Given this list of marker genes FNBP1, DNAJC9, HES6, RPL28, KIF2A, RHBDL3, MICOS13, MIS18A, ADPRS, TMEM214, MTRES1, RIC8A, PCMTD2, FOXJ2, FAM216A, KIF3A, SH3GL1, MRRF, FIG4, RNF121, RGS2, PDCD6, BET1, WDR45B, YBX1, ZNF395, ACOT13, ZKSCAN5, B3GALNT1, TRPV2, VPS26A, TP53BP1, ENTREP3 (NCBI Gene Id 149536), ELANE, AFF4, RNF138, SLC52A2, LTBR (lymphotoxin beta receptor), BRAP, LRRC40, SIN3A, PPOX, MCM2, OAZ2 (ornithine decarboxylase antizyme 2), ELAC2, ITCH, SEC61B, PARK7, NAGK, TDP2, TOR1A, TUBB2A, PEX12, LIME1, NCAPH, BMS1, JMJD1C, TNRC6A, CHFR, PPM1D, S100A8, HCFC1R1, LMNB2 (lamin B2), STAMBPL1, CKLF, TRIO, SDHAF4, GTF2I (general transcription factor IIi), GRHPR, WNT5A, MORN4, ABHD4, GPAM, TAGLN, ZNF318, TOPBP1, FAM91A1, MRPS12, IDH3G, ATOX1, PEDS1, N4BP2L1, HPF1 (histone PARylation factor 1), CARMIL1, SLC37A2, SCYL1, FITM1, PRKRA, NOL12, PER1, PLIN3, GAS6, CDK16, MRPS7, ZFP90 (NCBI Gene Id 146198), DBNDD2, NEAT1, BCL7B, TCTN3, RANBP10, NDUFA4, UBAC1 (UBA domain containing 1), RPL36, LACTB, RRAGC, NIP7, RCC2, CIBAR1, LZTR1, RPL38, COA6, PRMT3, PELO, SHPRH, ME2, MTIF2, HERC4, MCRIP1, COX6C, WRNIP1, KIN, NFX1, LPGAT1, RIPOR1, RPL26, MTG2, MPG, AURKAIP1, ARMC1, MED29, SPTSSA, SNX21 (sorting nexin family member 21), ARL16, GBA2, ZNF566, METTL9, ABHD17A, TRIM33, TCEA3, FAM50A, POLE3, SMIM19, ALDH1A2, NDUFA11, LMAN2, RAB24, RPL11, CDK1, FBXO25, SLC25A3, CA9, MAP3K11, RNF20, B4GALT3, POLR3G, EMILIN1, NENF, RPA1, RNASE4, ASB6, KPNA2, MED4 (mediator complex subunit 4), OLFM1, ARFIP2, RABL6, TPGS1, TSEN34, DCTN1, CCNB1IP1, GRK2, IER5, SLC30A9, FTSJ1, UBP1, ORMDL1 (NCBI Gene Id 94101), SNAP47, ELP3, AZGP1, RAB3GAP2, ZNF426, BEX3, ACTR8, TPD52L2, SSRP1, ALKBH4 (NCBI Gene Id 54784), NUP133, CBR3, VTI1B, OVCA2, ULK2, ABHD18, MMS22L (MMS22 like, DNA repair protein), C2orf42, LSM14B, BLTP3B, GFER, DNAJC3, BOD1L1, EGLN2, RSPRY1, here is a description of the gene set: Genes up-regulated in macrophages 24h after M. bovis BCG infection: wildtype versus MYD88 knockout. Human Gene Set: GSE22935_WT_VS_MYD88_KO_MACROPHAGE_24H_MBOVIS_BCG_STIM_UP Nitric oxide (NO) produced by macrophages (MØs) is toxic to both host tissues and invading pathogens and its regulation is therefore essential to suppress host cytotoxicity. MØ arginase 1 (Arg1) inhibits NO production by competing with NO synthases for arginine, the common substrate of NO synthases and arginases. Two signal transduction pathways control Arg1 expression in MØs. First, a MyD88-dependent pathway induces Arg1 in intracellular infections, while a second Stat6-dependent pathway is required for Arg1 expression in alternativelyactivated MØs. We found that mycobacteria-infected MØs produce soluble factors that induce Arg1 in an autocrine-paracrine manner via Stat3. We identify these factors as IL-6, IL-10 and GCSF. We further establish that Arg1 expression is controlled by the MyD88-dependent production of IL-6, IL-10 and G-CSF rather than cell intrinsic MyD88 signaling to Arg1. Our data reveal the MyD88-dependent pathway of Arg1induction following BCG infection requires Stat3 activation and may result in the development of an immunosuppressive niche in granulomas due to the induced Arg1 production in surrounding uninfected MØs studied in species Homo sapiens from publication Qualls JE, Neale G, Smith AM, Koo MS, DeFreitas AA, Zhang H, Kaplan G, Watowich SS, Murray PJ (PMID 20716764)